Given this list of marker genes PBX3, GRIA3, ALPK2, COX7A1, ANO4, CPXM2, GREM1, IGFBP5, STMN2, AP1S3, SPP1, COPZ2, DSEL, CNN1, SHOX2, RND2, MMP10, FBLN5, PRR5L, B4GALT4, MYL9, SLC16A2, MMP3, GALNT9, LBH, CRYAB, TK2, DDAH2, ODAPH (odontogenesis associated phosphoprotein), BMPER, NLRX1, APH1B, CPEB1, HSPB2, PRSS30P, SYNC, PVALB, TAGLN, SAMD9L, MYL5, COL11A1, MFGE8, TUBB2A, here is a description of the gene set: from publication Cowling VH, Cole MD (PMID 17704800) Genes down-regulated by MYCN but not by its transactivation-defficient, trunkated form N-Myc-delta-73. Human Gene Set: COWLING_MYCN_TARGETS studied in species Homo sapiens Myc promotes both normal cell proliferation and oncogenic transformation through the activation and repression of target genes. The c-Myc-S protein is a truncated form of c-Myc that is produced in some cells from translation initiation at an internal AUG codon. We report that c-Myc-S and a similar truncated form of N-MycWT can fully rescue the proliferation defect in myc-null fibroblasts, but rescue is dependent on the highly conserved Myc homology box II (MBII). Global gene expression studies show that the N-Myc equivalent of c-Myc-S is defective for virtually all transcriptional activation of Myc target genes but remains active for the majority of transcriptional repression. Repression by Myc-S is dependent on MBII, but it does not bind to several known nuclear cofactors. These data suggest that repression by Myc involves recruitment of a novel MBII-dependent cofactor.